Given this list of marker genes KRT19, DUSP6, PTPRK, MRAP2, ANXA8L1, GABRE, S100A8, KRT1, FXYD3, CSF2, LAMC2, GPX2, AKR1C3, F2RL1, AKR1C1, ADRB2, ALDH1A3, KRT13, LGALS7 (NCBI Gene Id 3963), KRT17, KRT6A, PTGS2, LMTK3, CAV2, MMP14, AREG, SPRR2C, ROPN1L, CXCL1, COL7A1, MAOA, FBN2, B3GNT5, KLHL13, PGAP4, S100A9, TFPI2, LIPG, SERPINB5, CALML3, GJB5, EFNB1, KRT14, ITGA6, KRT5, CSTA, EIF2B3, LAMB3, DSP, KLK10, SERPINB2, S100A2, PI3, SAA1, FASN, FGFBP1, SERPINE1, DSC3, CDH3, COL17A1, KRT15, BARX2 (BARX homeobox 2), KRT6B, CA2, SPRR1B, PTHLH, CAV1, PPP1R14C, TRIM29, CLDN8 (NCBI Gene Id 9073, claudin 8), LAMA3, DST, ITGB4, ANGPTL4, TENM2, DMRT2, TP63, TM4SF1, HAS3, KLK5, here is a description of the gene set: studied in species Homo sapiens Intermediate filaments and keratins. Human Gene Set: MODULE_357